The following is a description of a gene set: part of: Plasma lipoprotein remodeling As chylomicrons circulate in the body, they acquire molecules of apolipoproteins C and E, and through interaction with endothelial lipases can lose a large fraction of their triacylglycerol. These changes convert them to chylomicron remnants which bind to LDL receptors, primarily on the surfaces of liver cells, clearing them from the circulation. This whole sequence of events is rapid: the normal lifespan of a chylomicron is 30 - 60 minutes. species: Homo sapiens Reactome Pathway: Chylomicron remodeling, and this is the list of marker genes: APOC3, APOC2, APOA2, APOA4, GPIHBP1, APOB, APOE, APOA5, LPL, APOA1